The following is a description of a gene set: studied in species Mus musculus Negative regulation of MET activity Mouse Gene Set: REACTOME_NEGATIVE_REGULATION_OF_MET_ACTIVITY, and this is the list of marker genes: Hgs, Hgf, Ptpn2, Lrig1, Sh3gl3, Usp8, Uba52rt, Sh3gl2 (NCBI Gene Id 319329), Rps27a, Cbl, Met, Eps15, Ptprj, Ubb, Ptpn1, Grb2, Stam, Sh3kbp1, Ubc, Sh3gl1 (NCBI Gene Id 98055), Stam2, Uba52